Given this list of marker genes Gbf1, Zfp367, Hmcn1, Rab12, Morf4l2, Eif3a, Hif1a, Map4k3, Klf10, Mapre3, Nono, Reg3b, Ndc1, Trim2, Abi1, Smco3, Chl1, Zfp871, Hccs, Matr3, Fsd1l, Smarce1 (SWI/SNF related, matrix associated, actin dependent regulator of chromatin, subfamily e, member 1), Slc36a4, Dlgap1, Vkorc1l1, Ubr3, Sbspon, Hipk3, Senp8, Tnfaip1, Mstn, Trem4, Lin28b, Kif21a, Kif18a, Nek7, Psd3, Cyp2c50, Ifnlr1, Prl7a2, Ndufaf7, Zfp521, Zfp106, Gje1, Usp33, Mesd, Pde6b, Mecp2, Nudt11, Hnrnph3, Enc1, Plekhg3, Bmi1, Trim12c, here is a description of the gene set: from publication Chen Y, Wang X (PMID 31504780) Mouse Gene Set: MIR_1949 Genes predicted to be targets of miRBase v22 microRNA mmu_miR_1949 in miRDB v6.0 with MirTarget v4 prediction scores > 80 (high confidence targets). studied in species Mus musculus